Given this list of marker genes FGFBP1, SMPDL3B, CLDN4, SLC35A3, TMC4, TJP3, TMEM125, SH3YL1, CST6, WDFY1, SESTD1, ENDOD1, PRR15L, CRYBG1, PDE5A, CCDC149, RAB38, QSOX1 (quiescin sulfhydryl oxidase 1), MPZL2, BICDL2, ZNF649, HMGCL, SPINK2, ZNF681, KLK6, AIG1, LIMA1, LRATD2, CAPN8, DOK7, ADAM28, LRG1, RNF114, VAV3 (vav guanine nucleotide exchange factor 3), NHSL3, MARVELD3, BLNK, CCDC57, ZDHHC21, FRMD4B, PTK6, CAB39, ZNF506, TMPRSS4, GRAMD1C, SMAGP, ZIK1, KCNMB4, OCLNP1, EPHA1, LMO7, PLEKHF2, PSD4, C1orf21 (NCBI Gene Id 81563), EPPK1, GPR87, GRHL2-DT, SYTL5, KLC3, GCA, CLDN9, PIK3IP1, GALNT3, GRHL2, NECTIN4, SMIM22, MPP7, STK39, MBOAT1, LNX1, MFSD6, HS3ST1, STARD10, IKZF2, S100A16, AKTIP, TMEM30B, ZNF91, TMEM40 (NCBI Gene Id 55287), CLDN7, ARHGDIB, S100A14, EMB, GIRGL, ELMO3, MYO6, TACSTD2, ILRUN-AS1, CRYBG2, KRT15, MYO1D, PLEKHA7, PRRG2, IRF6, CCNG2, TSPAN1, RASEF, OVOL1, MAPK13, RBM47, ANXA9, EPN3, PPL, AP1M2, SPINT1, ZMYM6, BLACAT1, SRPX2, ZNF468, EPS8L2, ADK, WFDC3, TTC22, PRKCD, C1orf116, ATP5IF1, TJP2, ENPP5, SYTL1, GRHL3, ERBB3, TMEM45B, HSD17B7, CAPS, WEE1, SYNE4, SCEL, KRT19, RNF141, CRACDL, PRSS22, RAB25, NPNT, FXYD3, SVIL, ARAP2, SH3BGRL2, ANKRD22, COMT, UNC13D (unc-13 homolog D), TMEM54, STAP2 (NCBI Gene Id 55620), ZNF43, ENPP4, WLS, B3GNT3, BSPRY, CCDC115, C6orf132, VAMP8 (vesicle associated membrane protein 8), DAPP1, SPOPL, PEG10, MACC1, ST14, EXPH5, PRSS8, TMEM123, TC2N, RIPK4 (NCBI Gene Id 54101), LIPH, LGALS9, KANSL1-AS1 (NCBI Gene Id 644246), GNAS, TMEM265, ESRP2, CDH3, CNKSR1, ACP3, ELF3, ZNF600, SCAMP2, DST, REPS2, CDH1, KDF1, GCNT2 (NCBI Gene Id 880), MYH14, ERP27, SPINT1-AS1, OVOL2, AGR2, ALDH1A3, CGN, ADAP1, PRRG4, SLC44A3, EPS8L1, GUCY1B1, COBLL1, CYP2J2, LAD1, BIK, ZNF429 (zinc finger protein 429), MROH1, ITGB6, CENPU, FAM3C, SLC2A12, EHF, JUN-DT, ARFGEF3, ADGRF1, MAL2, MPZL3, GAB1 (GRB2 associated binding protein 1), GUK1, USP44, MST1R, SLC1A1, LAMC2, KIAA0040, RAB11FIP4, LSR, CDS1 (NCBI Gene Id 1040), TMC5, SMIM5, PITPNM3, ATP2C2, FGD4, KALRN, SPTLC3, GRHL1, FAM171B, DDR1, ZNF818P, GPR160, FAM110A, TBC1D8B (TBC1 domain family member 8B), RHOD, here is a description of the gene set: studied in species Homo sapiens Genes down-regulated in NSCLC (non-small cell lung carcinoma) cell lines resistant to gefitinib compared to the sensitive ones. from publication Coldren CD, Helfrich BA, Witta SE, Sugita M, Lapadat R, Zeng C, Barón A, Franklin WA, Hirsch FR, Geraci MW, Bunn PA Jr (PMID 16877703) Human Gene Set: COLDREN_GEFITINIB_RESISTANCE_DN Tyrosine kinase inhibitors (TKI) of the epidermal growth factor receptor (EGFR) produce objective responses in a minority of patients with advanced-stage non-small cell lung cancer (NSCLC), and about half of all treated patients progress within 6 weeks of instituting therapy. Because the target of these agents is known, it should be possible to develop biological predictors of response, but EGFR protein levels have not been proven useful as a predictor of TKI response in patients and the mechanism of primary resistance is unclear. We used microarray gene expression profiling to uncover a pattern of gene expression associated with sensitivity to EGFR-TKIs by comparing NSCLC cell lines that were either highly sensitive or highly resistant to gefitinib. This sensitivity-associated expression profile was used to predict gefitinib sensitivity in a panel of NSCLC cell lines with known gene expression profiles but unknown gefitinib sensitivity. Gefitinib sensitivity was then determined for members of this test panel, and the microarray-based sensitivity prediction was correct in eight of nine NSCLC cell lines. Gene and protein expression differences were confirmed with a combination of quantitative reverse transcription-PCR, flow cytometry, and immunohistochemistry. This gene expression pattern related to gefitinib sensitivity was independent from sensitivity associated with EGFR mutations. Several genes associated with sensitivity encode proteins involved in HER pathway signaling or pathways that interrelate to the HER signaling pathway. Some of these genes could be targets of pharmacologic interventions to overcome primary resistance.